The following is a description of a gene set: Human Gene Set: ONDER_CDH1_TARGETS_1_DN Genes down-regulated in HMLE cells (mmortalized nontransformed mammary epithelial) by expression of a dominant-negative form of E-cadhedrin (CDH1). studied in species Homo sapiens from publication Onder TT, Gupta PB, Mani SA, Yang J, Lander ES, Weinberg RA (PMID 18483246) Loss of the epithelial adhesion molecule E-cadherin is thought to enable metastasis by disrupting intercellular contacts-an early step in metastatic dissemination. To further investigate the molecular basis of this notion, we use two methods to inhibit E-cadherin function that distinguish between E-cadherin's cell-cell adhesion and intracellular signaling functions. Whereas the disruption of cell-cell contacts alone does not enable metastasis, the loss of E-cadherin protein does, through induction of an epithelial-to-mesenchymal transition, invasiveness, and anoikis resistance. We find the E-cadherin binding partner beta-catenin to be necessary, but not sufficient, for induction of these phenotypes. In addition, gene expression analysis shows that E-cadherin loss results in the induction of multiple transcription factors, at least one of which, Twist, is necessary for E-cadherin loss-induced metastasis. These findings indicate that E-cadherin loss in tumors contributes to metastatic dissemination by inducing wide-ranging transcriptional and functional changes., and this is the list of marker genes: B3GALNT1, DEPP1, SETMAR, NCBP1, TMPO, ANO1, SFPQ, CASP8, DCBLD2, CSF3, SRSF3, JAG1, HBEGF, CYB5R2, PPP2R1B, MFAP5, BCLAF1, IGFBP3, CANX, HMGCS1, MAX, P2RY2, IFIT5, CBFB, TOR1AIP1, ZNF365, MYO5C, IVL, PI3, SERPINB13, MTARC1, SERPINB1, IL1B, SLC16A1, KRT8, UTP20, B3GNT2, UTP14C, EDN1, MPHOSPH8, EPN3, CXCL8, CXCL1, BRCA2, H4C3, KRT13, UGCG, LARP4, SERPINB8 (serpin family B member 8), SERPINB2, S100A7, MEST, ALG13, UTP14A, SRSF2, IL36G, EHF, SCEL, HNRNPM, PHTF2, UMPS, CDC6, FOSL1, NUP98, PAFAH1B1, LCN2, KLK10, SCYL2, METAP2, TIPIN, RIOX1, PTHLH, ZMPSTE24, OSMR, NAP1L1, RNFT1, FBXO9, HNRNPU, DUSP6, IMP3, CEMIP2, HCCS (NCBI Gene Id 4307), TSEN2, GPRC5A, SPRR2A, ENC1, DKK1, SLC43A3, ATP12A, LCMT2, MCM4 (NCBI Gene Id 780917), CHRNA5, SUB1, LGALS8, ATP13A3, FERRY3, SOX9, RRS1, EIF5, SPAG1, MCM10, HS3ST2, WTAP, GLIPR1, PNO1, CRCT1, DSC2, MMP10, RBM12, FEN1, TGFA (transforming growth factor alpha), SEPTIN11, ILF3, IL1R2, RFWD3, HSPH1 (heat shock protein family H (Hsp110) member 1), CDC27, G3BP1, SKP2, PTGS2, KLF10, CXCL2, STARD13, POP1, KIF5B, HSPA8, TMPRSS11E, CXCL3, ADGRE2 (NCBI Gene Id 30817), ADAMTS1, MIR22HG, KLK7, CWH43, IL7R, EML4, FST, TP63, SMARCC1, CCNE2, POGLUT1, DDX18, ARHGAP25, DNAJA1, DHX9, BRIP1, TMX1, MAP4, ETS1, SYNCRIP, ST6GALNAC5, TOE1, EXOSC2, G3BP2, PRRC2C, NUP50, VGLL1, DDX52, CEACAM6, C1orf116, NAV3, ARL4C (NCBI Gene Id 10123), KRT34, KLK11, SP100, CALM1, IL6ST, CSF2, KRT15, DDX3X, EIF4G1